Given this list of marker genes RPS21, RPL37 (NCBI Gene Id 6167), RPLP2, EEF1A1, ERBB3, EPO, TMEM109, RPL27, WDR5, SMARCA2, AMH, RPL32, RPL5, LDHB, here is a description of the gene set: Human Gene Set: MODULE_429 Genes in the cancer module 429. species: Homo sapiens